Given this list of marker genes TUSC3, RPN1, RPN2, PDCD1LG2, OSTC, MAGT1, B3GNT3, UBA52, DAD1, DDOST, RPS27A, UBB, PDCD1, JAK1, STT3B, MIB2, CD274, STT3A, OST4, UBC, TMEM258, here is a description of the gene set: Reactome Pathway: PD-L1(CD274) glycosylation and translocation to plasma membrane studied in species Homo sapiens part of: Regulation of PD-L1(CD274) Post-translational modification PD-L1 (CD274) glycosylation plays a critical role in determining the protein function and stability. PD-L1 is N-glycosylated at N192, N200 and N219 by the OST complex in the ER lumen. This process is important for PD-L1 stability and inhibits its targeting for proteasomal degradation by GSK3B. Also, JAK1 activated by IL6 pathway positively regulates the glycosylation process by aiding in the process of recruiting endoplasmic reticulum-associated N-glycosyltransferase STT3A (part of the OST complex) to catalyse PD-L1 glycosylation. PD-L1 is phosphorylated by IL6-activated JAK1 at Tyr112 (Y112). This process aids in stabilizing the PD-L1 protein. PD-L1, once glycosylated in the ER lumen, get translocated to the Golgi complex for further glycosylation by and K63-ubiquitination by MIB2. Post Golgi, PD-L1 gets transported to the plasma membrane where it can bind with its receptor and induce immune tolerance.